Given this list of marker genes RASA1, AGL, NDUFA1, AHCYL1, CIB3, ITK, MMGT1, HNRNPA3, NACC1, USO1, GADD45GIP1, GNB4, CHRNA7, ODF2L (NCBI Gene Id 57489), MTMR1, HMGXB4, DHX58, TMEM247, GADD45A, FYB1, VASH2, CLIC6, ZFYVE9, KNOP1, RSRC2, LCMT1, WDR83OS, ANGPT2, PRR23A, DNAAF8, CSAD, MAP6, SPIN1, PFKFB4, CRK, FZD7, CCSER1, HOXA11-AS, CYRIA, CPA1, PGAM1, KIF13A, GIPC2, FAM204A, POGLUT3, LINC00511, LTA, PFDN2, MYT1L, VPS53, HMX1, ANKRD45, BRSK2, ABCC10, CASP8AP2, IL17RB, MCTP2, HOXA7, IL17RE, ZNF532, GABRG3 (NCBI Gene Id 653227), ACP1, RGS1, PRSS46P, SNORD89, ZNF616, YWHAH, NIT2, KRT27, WIPF2, FABP7, CLCN1, PDLIM5, ARHGEF16, ACSL3, CD200, SYT16, GSDME, CAPN11, DCAF12, OVOL1 (NCBI Gene Id 5017), MTMR10, WDFY1, CCDC97, ZC3HAV1 (NCBI Gene Id 79678), DDX42, KPNA3, DCST1, SMIM7, PDZK1, TIPRL, HOOK1, GALNT6, L1TD1, NDUFAF2, DMXL1, IRAG2, ATP6V1H, ACE2, MAPRE3, LACTB, PTS, KERA, USP25, PINK1, ZNF879, SIK1, RAB6B, DHRS1, TCAP, DDI2, SNX32, IRS4, LARGE2, TAF11, MORN3, OR51E1, C8G, SPATA18, B3GNT3, TRIM45, KLHL18, TPSG1, VPS37C, PRSS22, DENND2A, HEXB, PRDX2, DBT, PDE8B, DUSP4, C19orf44, CORO2A, MTSS1, TMEM252, BST2, SEPTIN11, DENND10, MISP, ITGB7, ZC3H12D, MICAL1, CCNB1IP1, TRPC4, RNF19B, KLK7, TNFAIP2, TBC1D25, DOCK3, MPHOSPH6, CFAP47 (cilia and flagella associated protein 47), SMIM6, CDC123, AMZ1 (NCBI Gene Id 155185), SLCO2B1, CD22, PACC1, FGL1, KDM4A, RPS6KA2, PAX4, NKRF, CFAP57, C1orf216, GKAP1, BMAL1, MYO1E, THOC1, FIBCD1, GREB1L, MARCHF6, SON, SLC24A4, MDGA1, MTREX, GXYLT1, DOC2A, GPT, FAM185A, HES6, NEDD4L, GNGT2, DLG3, UPK3BL1, MAP3K10, RHOJ, CD300LD, EPS8, ACP5, SRXN1, CDK20, NCOA4, BHMT2, IMPACT, DLGAP1, MCUR1, SEC24C, SLITRK1, PTHLH, ZNF706, here is a description of the gene set: from publication Feng J, Wang H, Shin DM, Masiuk M, Qi CF, Morse HC 3rd (PMID 21178004) Conditional IRF8 KO mice (mice with a conditional allele of Irf8 crossed with CD19-Cre mice) showed increased numbers of both Gene expression data spleen marginal zone (MZ) and Gene expression data spleen follicular (FO) B cells compared to control mice. To evaluate gene expression patterns that distinguished FO or MZ B cells derived from conditional KO and control mice, we used Affymetrix GeneChip® Mouse gene 1.0 ST Array. Human Gene Set: GSE24972_MARGINAL_ZONE_BCELL_VS_FOLLICULAR_BCELL_UP Genes up-regulated in speen B lymphocytes: marginal zone versus follicular. studied in species Homo sapiens